The following is a description of a gene set: The transcriptome of naive OT-I T cells was compared to memory CD8 T cells after 1, 2, 3, or 4 infection with ovalbumin expressing Listeria monocytogenes (LM-OVA). Genes up-regulated in memory CD8 T cells: 1' versus 4'. species: Homo sapiens from publication Wirth TC, Xue HH, Rai D, Sabel JT, Bair T, Harty JT, Badovinac VP (PMID 20619696) Human Gene Set: GSE21360_PRIMARY_VS_QUATERNARY_MEMORY_CD8_TCELL_UP, and this is the list of marker genes: ZCCHC2, DDX60, TRIM25, CCL2 (C-C motif chemokine ligand 2), LGALS3BP, FBXO32, MTHFD2, IKBKG, LGALS3, FOS, RASSF4, IL2RG, TMEM50A, NQO1, HPGD, SLC6A8, HPSE, ZC3H12C, MLKL, IRF7, P2RX4, TNIP3, ATP6V0A1, RILPL2, CD83, MED11, CYTIP, SAMD9L, DUSP9, DNMT3A, LMNA, PTCHD1, IFIT3, SPIC, SLC11A2 (solute carrier family 11 member 2), CYB5A, CSTB, TTYH2, RNY3, AHNAK, SERPINE1, TNFAIP2, SQSTM1, ANXA5, TNS3, FLNA, RIGI, FABP4, CLEC7A (NCBI Gene Id 64581), XAF1, GSTM1, CPEB4, MOV10, MMP13 (matrix metallopeptidase 13), LY9, DOT1L, CCDC50, ELF2, WASF1, ASNS, SRXN1, OXCT1, RASA4, BRI3, RNF144B, COX4I1, TGFBR1, PENK, LY6E, EEPD1, CLEC4D, TREML4, RGS1, CYBB, PLK2, PPARG, CCL5, TFRC, AMDHD2, IFIT2, IFI44, CLEC4E, PDE7B, GNS, SLAMF7, ADGRE5, GPNMB, GLTP, CLIC4, PDLIM4, ANKRD55, PLEKHM1, CD36, CD300LB, ANXA4, KIR3DL2, MGLL, S100A10, MYO1F, ST3GAL1 (ST3 beta-galactoside alpha-2,3-sialyltransferase 1), ZFAND2A, LY6S, RNF213, PTMS, OGT, PTGR1, GPR162, IL6ST, MARCHF3, USP18, GPR157, ZNFX1, PDP1, LRP12, XRCC1, C3, HERC5, IL1RN, LONRF3, EGR2, RSAD2, PRKCD, ASCC3, CD9, CXCL3, PLXNC1, GPR137B, CD74, ALAS1, NR2F6, GDF15, TNFSF4, ANPEP, ODC1, SAMHD1 (SAM and HD domain containing deoxynucleoside triphosphate triphosphohydrolase 1), STAP1, ADGRE4P, PMP22, LTF, CACNA1A, PML, AMDHD1, GABARAPL1, CRIP1, EMP1, ENTPD1, LAPTM4A, VWF, PTPRJ, MYOF, CD180, VAT1, COQ10A, STAT1, CMPK2, MMP8, SCPEP1, IL1RL2, IGF1, LY75, PACS2, IFIT1, MET, ENGASE, ATF3, UBE2L6, LPL, PLD3, SLC15A4, WDR91, ATP6V0D2, ABCC5, GAS7, IFITM3, SLC7A1